The following is a description of a gene set: studied in species Mus musculus The Emu-myc transgenic mouse has provided a valuable model for the study of B-cell lymphoma. Making use of gene expression analysis and, in particular, expression signatures of cell signaling pathway activation, we now show that several forms of B lymphoma can be identified in the Emu-myc mice associated with time of tumor onset. Furthermore, one form of Emu-myc tumor with pre-B character is shown to resemble human Burkitt lymphoma, whereas others exhibit more differentiated B-cell characteristics and show similarity with human diffuse large B-cell lymphoma in the pattern of gene expression, as well as oncogenic pathway activation. Importantly, we show that signatures of oncogenic pathway activity provide further dissection of the spectrum of diffuse large B-cell lymphoma, identifying a subset of patients who have very poor prognosis and could benefit from more aggressive or novel therapeutic strategies. Taken together, these studies provide insight into the complexity of the oncogenic process and a novel strategy for dissecting the heterogeneity of B lymphoma. from publication Mori S, Rempel RE, Chang JT, Yao G, Lagoo AS, Potti A, Bild A, Nevins JR (PMID 18922927) Down-regulated genes in the B lymphocyte developmental signature, based on expression profiling of lymphomas from the Emu-myc transgenic mice: plasma cell. Human Gene Set: MORI_PLASMA_CELL_DN, and this is the list of marker genes: BCL11A, GPATCH2L, ANP32A, REL, CALM2, DTX1 (deltex E3 ubiquitin ligase 1), ELK3, MTA3, TNFRSF13C, KLHL6, MICAL1, GPR137B, IL4I1, SMIM14, ARPC5L, LMO2, SMAD1, CD40, COTL1, PANK2, TPM4, SRPK3, MS4A1, ABLIM1, CPM, PIK3AP1, TLR1, CD83, CD22, LAPTM5, SPIB, BMP2K, TESPA1, LRCH1, BACH2